Given this list of marker genes PDZD2, LYRM2, TANGO6, PPDPF, SH2B2, ZHX2, ACTR6, CLDN14, CFL2, SLC7A6OS, SERPINB3, EPB41L4A, MDM1, ZNF655, OGDHL, ABCA5, VAPB, LGI2, EDDM3B, DOP1B, CD93, KIAA1210, CRNN, SSX3, KLHL41, EIF2AK4, MYOT, KLF1, TRIT1, TRIM5, CCDC62, NRIP3, CDHR2, NAA50, MMP27, DLGAP2, ACP4, GOSR1, LRRN3, ACTR3B, GIMAP5, LEAP2 (NCBI Gene Id 116842), TH, AGBL5, DNAJC27, TFB1M, NTRK3, SMARCAD1, TLR9, TSKU, HINFP, CARD18 (NCBI Gene Id 59082), NSD1, INSIG1, GAL3ST3, SIPA1L2, PPP1R17, MRPL36, TMEM45A, DPEP2, SMO, SIK3, MED8, DENND5A, CDYL, TRPM1 (NCBI Gene Id 4308), GALNT13, FA2H, UBE2T, NDE1, GJB5, RASGRP3, RPH3A, CENPJ, ZMYM6, ACTN2, PDE8A, HPN, DUS4L, SPOCK3, ARID2, BUB1B, FMNL2, ANKRD13A (NCBI Gene Id 88455), MSH5, ZFP91, GPRC5D, TOX4, DDHD1, DYNC1I1, FOXG1, BAG2, VDAC3, ENTREP2, FOXF2, FGL1, NDUFC1, LINC01549, TRAF7, TF, CYP26A1, ST8SIA5, WNT6, BBOX1, LANCL1, LTV1, SNTG2, LINGO1, CNTNAP2, PECR, E2F1, DHX58, SLC22A16, SPG11, ARHGEF25, COPE, SVIL, MTHFD1L, NIFK, IQCA1 (IQ motif containing with AAA domain 1), ANGEL1, MRRF, FBXO34, CALML3, SLC4A5, GDAP1L1, ZNF83, KCND1, SST, RTN2, AQR, PHLPP2, DNAJC14, SEZ6L2, MS4A14, LINC00869, PDE8B, FLRT3, PRTFDC1, PANK1, AFG2B, GDA, SYT6, HOXC10, ADCK2, RANBP17, MARCO, APBB1IP (NCBI Gene Id 54518), ERVH48-1, HSPA4L, TYW1, KHDC1, CNTNAP5, SRGAP3, ZKSCAN5, CLOCK, CDKL3, NAGPA, MSTO1, RBCK1, NUDT3, ST18, PDGFD, ATG4D, CAP2, MPP2, SERTAD4, CPNE4, IFT57, THOC2, RBP4, DIP2C, LIM2, SNTG1, CSDC2, NSFL1C, RPAP1, ARMCX5, TMEM144, MAP3K13, PHF24, CSGALNACT2, DISC1, AKAP3, STRA6, RBFOX2, KLHL20 (kelch like family member 20), JPH4, ZRANB1, EMC9, PRPSAP2, AQP9, HEBP1, TFR2, INTS13, ATPAF2, TMEM163, MGA, DDIT3, PBRM1, CYP46A1, AP1S2, LRTM1, ECEL1, FAHD2A, FAIM2, CLEC3A, OLFML2B, AFAP1-AS1, PAXBP1, POLE2, MRPL39, NECTIN1, AAR2, CD99L2, B3GNT3, MRPL13, NLN, FAXC, KIFC3, ERO1B, RAN, ST6GALNAC5, FARP2, MZB1, SMURF2, here is a description of the gene set: Human Gene Set: MODULE_207 studied in species Homo sapiens Genes in the cancer module 207.